Given this list of marker genes Bnipl, Tmprss4, Wrn, Ghrl, Ahr, Armc10, Parp1, Rftn1, here is a description of the gene set: species: Mus musculus Any process that modulates the rate of growth of all or part of an organism. Mouse Gene Set: GOBP_REGULATION_OF_GROWTH_RATE